Given this list of marker genes Runx2, Itgae, Il10, Tnfsf8, Rbl1, Cd81, Il17a, Cxcr3, Socs3, Ccr8, Gpr83, Cdk6, Il4, Ccr5, Ccr7, Cd84, Sgo1, Igfbp4, Ccl5, Il17ra, Ffar2 (free fatty acid receptor 2), Izumo1r, Tcf3, Parp1, Il21, Crem, Sell, Irf4, Socs2, Ctla2b, Slfn1, Il4ra, Adgre5, Foxn3, Ly6c1, Ccr2, Casp4, Runx3, Tnfrsf25, Tnfrsf18 (NCBI Gene Id 21936), Slfn2, Cxcr4, Slamf6, here is a description of the gene set: Naturally arising CD25+CD4+ regulatory T cells (T(R) cells) are engaged in the maintenance of immunological self-tolerance and immune homeostasis by suppressing aberrant or excessive immune responses, such as autoimmune disease and allergy. T(R) cells specifically express the transcription factor Foxp3, a key regulator of T(R)-cell development and function. Ectopic expression of Foxp3 in conventional T cells is indeed sufficient to confer suppressive activity, repress the production of cytokines such as interleukin-2 (IL-2) and interferon-gamma (IFN-gamma), and upregulate T(R)-cell-associated molecules such as CD25, cytotoxic T-lymphocyte-associated antigen-4, and glucocorticoid-induced TNF-receptor-family-related protein. However, the method by which Foxp3 controls these molecular events has yet to be explained. Here we show that the transcription factor AML1 (acute myeloid leukaemia 1)/Runx1 (Runt-related transcription factor 1), which is crucially required for normal haematopoiesis including thymic T-cell development, activates IL-2 and IFN-gamma gene expression in conventional CD4+ T cells through binding to their respective promoters. In natural T(R) cells, Foxp3 interacts physically with AML1. Several lines of evidence support a model in which the interaction suppresses IL-2 and IFN-gamma production, upregulates T(R)-cell-associated molecules, and exerts suppressive activity. This transcriptional control of T(R)-cell function by an interaction between Foxp3 and AML1 can be exploited to control physiological and pathological T-cell-mediated immune responses. studied in species Mus musculus Mouse Gene Set: ONO_AML1_TARGETS_DN Genes down-regulated in CD4+ T lymphocytes by expression of AML1 off a viral vector. from publication Ono M, Yaguchi H, Ohkura N, Kitabayashi I, Nagamura Y, Nomura T, Miyachi Y, Tsukada T, Sakaguchi S (PMID 17377532)